The following is a description of a gene set: Mouse Gene Set: MIR_7240_5P from publication Chen Y, Wang X (PMID 31504780) Genes predicted to be targets of miRBase v22 microRNA mmu_miR_7240_5p in miRDB v6.0 with MirTarget v4 prediction scores > 80 (high confidence targets). studied in species Mus musculus, and this is the list of marker genes: Klrg1, Zfp973, Sertad4, Rere, Zxdb, Lfng, Rassf4, Ints12, Tcf12, Slc24a2, Pcdh10, Plekhh1, Dnm1, Timm23, Tpgs2, Kcne1 (NCBI Gene Id 16509), Xkr6, Cgn, Sidt2, Mical2, Bcl2l2, Trappc9, Ccr1, Adam2, Tubb4a, Cpne6, Pik3cb (phosphatidylinositol-4,5-bisphosphate 3-kinase catalytic subunit beta), Fcgr4, Hic2, Svs3b, Klk5, Zfp157, Arl14epl, Pcdh15, Zcchc14, Dab2ip, Casr, Ldlrad3, Zfp965, Ralgps1, Nucb2, Elmod2 (NCBI Gene Id 244548), Tspan11, Pcdh9, Klhl34, Xpr1, Prss37, Cep120, Ankfy1, Spout1, Ankrd22, Csnk1g1, Gpr45, Coro2b, Slc9a1, Dusp15, Rbm14, Rhbdl3, Plekhg4, Lin7a, Soat2, Greb1l, Krt71 (NCBI Gene Id 56735), Marchf6, Ago1, Dhh, Dars1, Igf1, Opa1, Xylt2, Apcdd1, Ephb2, Hnrnpu, Chsy1, Pcna, Pde1a, Gjd4, Sgms1, Magi2, Syn1, Zscan20 (zinc finger and SCAN domains 20), Hpse2, Phldb1, Zfp704, Asrgl1, Rbp3, Tmed5, Gpr21, Lrrcc1, Syt11, Ube2d2b, Ctf1, Elp4, Robo2, Msx3, Selenoo, Atp11b, Camta1, Cbfa2t3, Ralgapb, Ikbkg